Given this list of marker genes SHTN1, P2RY12, CD2AP, NTN1, NRP1, CTTN, SDCBP, OPHN1, NCK1, MYH10, here is a description of the gene set: species: Homo sapiens Human Gene Set: GOBP_SUBSTRATE_DEPENDENT_CELL_MIGRATION_CELL_EXTENSION The formation of a cell surface protrusion, such as a lamellipodium or filopodium, at the leading edge of a migrating cell.